Given this list of marker genes HNMT, CHPT1, CASP3, GRIN2A, GRIN1, BHMT, DNMT3B, CYCS, DNMT1, PEMT, GRIN2D, NDUFAF7, ALDH7A1, PCYT1A, EHMT1, DNMT3A, MARS1, COMT, CHDH, ASMT, MTHFR, EHMT2, CHKA, CASP9, here is a description of the gene set: Human Gene Set: WP_MTHFR_DEFICIENCY species: Homo sapiens MTHFR deficiency